Given this list of marker genes BCOR, DHCR7, ZDHHC9, NKX6-2, ACTA1, IGF2, NOTCH3, COL5A1, HACD1, LOX, ANKH, SCN4A, SATB2, SMAD2, MAP3K20, EMC10, LZTFL1, TPM2, GNAI3, GNB2, BBS10, SCUBE3, ITGA7, ZBTB7A, CCDC47, IFT27, GRB10, ABL1, SELENON, BBS4, BBS7, WDPCP, NAA10, BBS2, PCGF2, TRIM37, EP300, POLD1, PUS7, XYLT1, FREM2, CEP19, BBS5, C12orf57, SPEN, EDNRA, TAF6, PLCB4, SOBP, BANF1, IL6ST, DDR2 (discoidin domain receptor tyrosine kinase 2), MYMX, RPL10, BMP2, MYH3, GJA1, H19, EDN1, BBS9, BBS1, AMER1, MYL2, FRAS1, UPF3B, NSDHL, MADD, GRIP1, SCARF2, FGFR2, RPS6KA3, ZFX, TECPR2, BBIP1, CEP290, SOX5, SDCCAG8, DVL1, FGFR1, CAMK2B, PEX6, IL1RAPL1 (interleukin 1 receptor accessory protein like 1), IL11RA, WBP4, IFT74, BBS12, CEP295, SPECC1L, AMMECR1, SCAPER, RAP1B, ZEB2, KIDINS220, CBS, FBN1, MASP1, SETBP1 (NCBI Gene Id 284262), TOMM7, KCNJ5, MED12, MKKS, SCLT1, ATP6V1E1, ATR, ZMPSTE24, DSE, KIF15, COL1A2, OCRL, PIGK, PRMT7, SMC1A, TPM3, FLCN, TRPS1 (transcriptional repressor GATA binding 1), CREBBP, LMNA, RECQL, MGAT2, PLOD1, SETD5, SET, ASXL3, MKS1, LIG4, INSR, TRIM32, HNRNPH1, SMS, NPHP1, NSUN2, LGI4, KCNJ2, ARL6, TTC8, CCDC28B, IFT172, CFAP418 (NCBI Gene Id 157657), EFEMP1, WNT5A, TRIO, COL3A1, ROR2, SNX14, ADAMTS15, NONO, NEDD4L, here is a description of the gene set: Changes in alignment of teeth in the dental arch Human Gene Set: HP_DENTAL_CROWDING species: Homo sapiens Dental crowding